Given this list of marker genes KCNN4, HIP1R, FRMD4B, AIF1L, EPB41L5, NF2, FGD6, EEF1A1 (NCBI Gene Id 96648), ADAM17, PODXL, AMOT, ARHGAP1, MTMR6, CDKL5, PTK6, ARFIP2, JCAD, PARD6A, KANK1, SH2D3C, THEM4, LAYN, S100B, SPRY2, FGD1, SNX5, PAK1, PLCG1, PDE9A, PLA2G4F, SH3BGRL3 (NCBI Gene Id 83442), FGR, SPRY4, PSD2, RDX, PPP1R9B, S100A6, MTSS1, INPP5E, EGFR, TMEM87A, TLR4, KNSTRN, SH2B2, EZR, RAC1, FAM107A, EPS8L1, CLCN3 (NCBI Gene Id 133073), BMX, LCP1, MYH9, MYADM, CORO1C, PTPRJ, PLCG2, RIGI (NCBI Gene Id 23586), FAP, FGD3, RAB34, SH3YL1, MEFV, KLHL2, MTMR9, DLC1 (DLC1 Rho GTPase activating protein), CLASP2, RAB5A, PSD, ARHGEF4, MACF1, ACTN1, TPM1, CSPG4, PSD3, PDPN, AIF1, FERMT1, ARF4, ABCA7, PLEKHO1, MTM1, APPL1, TIRAP, ITGB3, RINL, VIL1, PALLD, CD2AP, CDK6, FGD5 (NCBI Gene Id 152273), NME2, EPS8L2, GNAS, RASA1, APC, MKLN1, MYO6, LIMA1, S100A11, FSCN1, EPHA2, AKT2, PDLIM7, IFIT5, MTMR14, ARHGEF26, CFL1, BCAR1, ATP6V1B2, WWC1, SAMSN1, NHERF1 (NCBI Gene Id 9368), ERBB2, CARMIL2 (NCBI Gene Id 146206), RPS3, PDXP (pyridoxal phosphatase), MYO9B, CLIP1, SNX9, CYFIP1, KLHL41, KSR1, PLEKHA1, ARAP1, RAB22A, PACSIN2, INPP5J, ROCK1, PIP5K1C, ARHGAP18, TLN1, CAPG, PDE4A, DBNL, ADGRE2, PACSIN1, ITGAV, WIPF1, COBL, CTTN, MTSS2, SRC, ACAP2 (NCBI Gene Id 23527), NCKAP1, BLOC1S6, TRPV4, TNFRSF12A, TESC, TRPM7, ALS2, ITGB1, ARAP3, ARHGAP45, ASAP3, CYTH3, APPL2, FGD4, EPS8, PIP5K1A, INPP5K, SCIMP, FSCN3 (fascin actin-bundling protein 3), ABL1, TWF1, PSD4, ARHGEF7, ITGB1BP1, FGD2, BAIAP2, IQGAP1, EPS8L3, ARHGEF2, MYO10, MYO1C, ITGA5, RASGRP2, PLEK, KIF18A, SPATA13, DIAPH1, MYO5A, C2CD5, NME1, TLN2, ARF6, RHOA, CIB1, SNTG1, WASF2, here is a description of the gene set: Projection at the leading edge of a crawling cell; the protrusions are supported by a microfilament meshwork. Human Gene Set: GOCC_RUFFLE species: Homo sapiens